The following is a description of a gene set: Mouse Gene Set: GOMF_DNA_CLAMP_LOADER_ACTIVITY species: Mus musculus Facilitating the opening of the ring structure of the PCNA complex, or any of the related sliding clamp complexes, and their closing around the DNA duplex, driven by ATP hydrolysis., and this is the list of marker genes: Rfc4, Chtf18, Rfc3, Rfc1, Rad17, Rfc5, Dscc1, Rfc2, Chtf8